The following is a description of a gene set: Human Gene Set: GSE3039_CD4_TCELL_VS_B1_BCELL_DN Three innate (B1-B, NKT, CD8aaT cells) and adaptive (B2-B, CD4T, CD8abT cells) cell-types were sorted by FACS. Three biological replicates for NKT, CD4T, CD8aaT, CD8abT cells and two biological replicates for B1 and B2 cells were generated and the expression profiles were determined using Affymetrix Mu74Av2 chip. Comparisons between the sample groups allow the identification of genes differentially expressed between the innate and adaptive cell-types. species: Homo sapiens Genes down-regulated in CD4 T cells versus B1 B lymphocytes. from publication Yamagata T, Benoist C, Mathis D (PMID 16623764), and this is the list of marker genes: CCDC25, CD53, SLC39A2, EMB, KIF2B, TMEM98, ZBED5, CEBPB, USP2, OIT3, SPHK1, CTSV, CD300C, STX7, CLIP2, GSTO2, MPST, HTRA4, PROK2, KCNN3, ADRB1, TXNIP, IL4R, LAMP1, UCP3, IL12RB2, DNASE2B, CFAP141, TMEM38B, HS1BP3, TPD52, YPEL3, CFAP206, BST1, PISD, PAXX, SOD2, CCBE1, SH3BGRL2, GSTM5, TMEM86A, SLPI, SELENOW, ZNF846, AOPEP, PABPC1L, CSF3R, TST, ACP2, GABARAP, PLIN2, RHOA, SDCBP (syndecan binding protein), PFN1, CLEC7A, MYL12B, SLC35F3, ADI1, C19orf12, MR1 (major histocompatibility complex, class I-related), CD44, CNTNAP1, GLIPR2, GALNT14, MMP8, RARRES1, CD93, SLC11A1, GDPD1, KDM4B, ATP6V0C, FURIN, SHARPIN, B2M, RAP2B, FNIP2, ATP13A2, CABLES1, GPATCH3, LPCAT2, KLHDC4, SPP1, TNFAIP8, TAFAZZIN, MCOLN1, C15orf61, PIK3AP1, ANGPTL2, STOM, INKA2, CLEC4D, CD33, SIRPA, F10, MSRB1, CMKLR1, GPRC5B, MPEG1, ZFP2, S100B, HPRT1, CTSC, H3C14, GNPDA1, AP3S1, SLC38A7, CD9, TLR8, CTSD, PPIA, CAP1, ATP6V1G2, CCR1 (NCBI Gene Id 1230), TYROBP, MCL1, NDUFA3, SLC6A8, FPR1, TTPA, CYRIB, SNCG, UPP1, CTSB, KRT25, FER, CD180, CCL4, DYNLT4, DLEU7, NDUFA7, FCER1G, GLRX, FTH1, GPR152, CD302 (NCBI Gene Id 9936), IL1RN, MCAM, SGSH, FOXC2, MAGEF1, HPGDS, MIR1915HG, ZNF473, MTG2 (mitochondrial ribosome associated GTPase 2), MORN5, HLA-C, IL1B, C6orf15, MSN, TMEM106B, ADIPOR1 (adiponectin receptor 1), KIAA0319L (NCBI Gene Id 79932), TEX22, GOLPH3L, HYAL4, MEFV (NCBI Gene Id 4210), PLEKHM2, ITM2B, CTSK, ATP6AP1, VMP1, HP, PGLYRP2, ANXA5, HSPA1L, NEAT1, BTG1, LHFPL2, LY9, CD47, LY6E, OLIG2, SIRPB1, C8orf74, IL12A, MORC4, TLR2, LRMDA, SDHAF2, PIWIL2, COG2, ARG2, MT1E, TIMP2, NEK6, PIGB, MT2A (NCBI Gene Id 4502), SMKR1, IER3, GGT1, SRSF12, EIF5A, ABHD4, RAVER1, SLC31A2, ANO9, CSF1, RAPGEF5, C9orf43, MPP1